Given this list of marker genes Arhgef37, Arhgef7, Mapk8, Arhgef17, Arhgef10, Gna13, Arhgef10l, Arhgef15, Arhgef39, Arhgef38, Ngef, Arhgef1, Vav1, Itsn1 (NCBI Gene Id 16443), Arhgef3, Arhgef12, Arhgef33, Bad, Sos2, Fgd1, Fgd2, Prex1 (NCBI Gene Id 277360), here is a description of the gene set: Reactome Pathway: NRAGE signals death through JNK species: Mus musculus This event has been computationally inferred from an event that has been demonstrated in another species.<p>The inference is based on the homology mapping from PANTHER. Briefly, reactions for which all involved PhysicalEntities (in input, output and catalyst) have a mapped orthologue/paralogue (for complexes at least 75% of components must have a mapping) are inferred to the other species. part of: Cell death signalling via NRAGE, NRIF and NADE electronically inferred by orthology from the curated human pathway